Given this list of marker genes BMS1, TMEM19, WDR74, RAP1A, IFT74, IFIT1, ANAPC5, TTC4, GUCY2C, METTL4, PFN2, CRHBP, OTUD6B, CSTF1, EIF2D, AP1AR, RSL1D1, HDAC2, PEX2, GTF2F2, LRP8, OVCA2, CCDC34, SRP19, ORC4 (origin recognition complex subunit 4), CMTR2, STARD4, SMIM3, ASH2L, MRPL32, NDUFA7, RNF121, MSH2, RAD17, ZPR1, ARK2C (NCBI Gene Id 494470), ANAPC11, URB2, RFC1 (replication factor C subunit 1), CCNC, PPHLN1, GOLT1B, DDB1, KPNA6, ZNF708, RIOX2, DARS2, AGFG1, FASTKD2, NDUFB3, POLD3, PEX16, ENKD1, RCC1L, GLI2, WDR43, NDUFA2, POFUT1, GUK1, NUDC, REEP4, TEX261, DARS1, MED27, SIKE1 (NCBI Gene Id 80143), BET1, PSMD3, RIPK1 (NCBI Gene Id 8737), PSMC3, WDR36, MTO1, FAF1, PSMD13, KHSRP, BBS10, BCAP29, CMSS1, AFP, SLC35F2, HINT1, BCL2L13, DRG1, ANAPC15, UTP25, DBT, ZBP1, GLMN, KATNB1, ACY1, RTP4, ADH5, ARFIP2, XRCC5, THOC5, SPCS1, CCN6, YWHAQ, LSM7, HSD17B7, DZIP3, ASB5, SRP54, CSNK2A2, UBE2I, EED, RBBP9, DTX3L, ESF1, ALAS1, CDC123, ERO1A, WDR3, ARL6, EDC3, ZC3HAV1, PARP9, ARV1, SAR1B, CLTB, FAM177A1, ERI3, MESD, MRPS24, AIFM1, ACTR3B, SLC29A2, SUCLA2, LETM1, ALG5, RSL24D1, BCCIP, TSR3, HSPA13, MRPL55, SNRNP40, MTMR14, HOOK2, BAG2, INTS4, TBRG4, TXNL4A, YTHDF2, APOBEC3B, HAUS4, TSN, NPAT (nuclear protein, coactivator of histone transcription), DPP3, MTRR, MAP2K2, MKKS, PKIB, PGAM5, PCCA, COX17, PCTP, NDUFS1, ACP1, PREP, HMGCR, MED18, TRIM14 (tripartite motif containing 14), COX6B1, LMNB1, HASPIN, CLPX, OST4, SHCBP1, ALG6, SDR39U1, CEP55, PCCB, GYPC, NCBP1, NPNT, TAF12, UBE2M, PPIA, SEPHS2, SPART, PFDN2, POGK, RGS12, BUD23, TSSC4, MBD3, UBXN2B (UBX domain protein 2B), NSMCE1, TMEM201, RPUSD3, UQCRC2, DDX27, CBX3, NUCKS1, MFN2, ATP5MF, MRPS25, FABP5, GALE, TPD52L2, ZNF322, here is a description of the gene set: During acute viral infections, naïve CD8+ T cells differentiate into effector CD8+ T cells and, after viral control, into memory CD8+ T cells. Memory CD8+ T cells are highly functional, proliferate rapidly upon reinfection and persist long-term without antigen. In contrast, during chronic infections, CD8+ T cells become “exhausted” and have poor effector function, express multiple inhibitory receptors, possess low proliferative capacity, and cannot persist without antigen. To compare the development of functional memory T cells with poorly functional exhausted T cells, we generated longitudinal transcriptional profiles for each. Human Gene Set: GSE41867_DAY8_EFFECTOR_VS_DAY30_MEMORY_CD8_TCELL_LCMV_ARMSTRONG_UP from publication Doering TA, Crawford A, Angelosanto JM, Paley MA, Ziegler CG, Wherry EJ (PMID 23159438) Genes up-regulated in CD8 T cells, acute infection with LCMV-Armstrong: effectors at day 8 versus memory at day 30. studied in species Homo sapiens